Given this list of marker genes Igf2bp1, Hnrnpu, Dhx9, Tent4b, Cnot7, Tnrc6c (trinucleotide repeat containing 6C), Zfp36, Hnrnpd, Cnot1, Tnrc6b, Ago2, Syncrip, Paip1, Pabpc1, Tent4a, Rc3h1, Cpeb3, Tnrc6a, Zfp36l1, Dhx36, Csde1, Ybx1, Zfp36l2, Tob1, here is a description of the gene set: Any process that modulates the frequency, rate or extent of nuclear-transcribed mRNA catabolic process, deadenylation-dependent decay. Mouse Gene Set: GOBP_REGULATION_OF_NUCLEAR_TRANSCRIBED_MRNA_CATABOLIC_PROCESS_DEADENYLATION_DEPENDENT_DECAY studied in species Mus musculus